The following is a description of a gene set: The action of a molecule that contributes to the structural integrity of the lens of an eye. Mouse Gene Set: GOMF_STRUCTURAL_CONSTITUENT_OF_EYE_LENS species: Mus musculus, and this is the list of marker genes: Crybb2, Bfsp1, Crybb3, Cryaa, Crybb1, Lim2, Hspb2, Crybg3, Crygb, Cryba2, Cpox (NCBI Gene Id 436366), Crygf, Crygc, Cryab, Hspb6, Cryga, Cryba1, Mip, Bfsp2, Crygd, Cryba4, Vim, Crygn, Cryge, Crygs